Given this list of marker genes VCL, PNPLA2, LMOD2, ALPK3, DOLK, DSP, RYR1 (NCBI Gene Id 906), RPL3L, TNNI3, GYG1, COA5, ACTN2, TNNT2, KLHL24, ACTC1, CACNA1S, here is a description of the gene set: Abnormal cardiomyocyte morphology Human Gene Set: HP_ABNORMAL_CARDIOMYOCYTE_MORPHOLOGY studied in species Homo sapiens Any structural anomaly of cardiomyocytes, which are terminally differentiated muscle cells in the heart that are interconnected end to end by gap junctions, which allows coordinated contraction of heart tissue.